Given this list of marker genes PRICKLE4, PDLIM3, PDLIM2, PDLIM5, PKD2L1, PKD2, NRAP, PDLIM7, PALLD (palladin, cytoskeletal associated protein), SYNPO2, PDLIM1, LDB3, PDLIM4, TTN, MYPN, here is a description of the gene set: Human Gene Set: GOMF_MUSCLE_ALPHA_ACTININ_BINDING species: Homo sapiens Binding to muscle isoforms of actinin. Muscle alpha-actinin isoforms are found in skeletal and cardiac muscle and are localized to the Z-disc.